The following is a description of a gene set: studied in species Homo sapiens Human Gene Set: GOBP_PHOSPHOLIPID_TRANSPORT The directed movement of phospholipids into, out of or within a cell, or between cells, by means of some agent such as a transporter or pore. Phospholipids are any lipids containing phosphoric acid as a mono- or diester., and this is the list of marker genes: TNFAIP8L3, OSBP, LDLR, ABCA4, PLSCR2, CPTP (ceramide-1-phosphate transfer protein), ABCA12, PLTP, PITPNB, C2CD2L, ATP10B, APOC2, CETP, ABCB4, MFSD2A, PITPNA, VDAC2, SLC66A2, OSBPL2, ESYT1, TMEM41B, VMP1, PRELID3B, ANO4, APOA5, APOC3, SCP2, SERINC3, ATP8A1 (ATPase phospholipid transporting 8A1), SPNS1, ATP8B2, P2RX7, CERT1, PITPNC1, XKR7, APOA1, PLSCR5, PCTP (NCBI Gene Id 94001), ETNPPL (ethanolamine-phosphate phospho-lyase, NCBI Gene Id 64850), ATP11B, XKR8, CLPTM1L, PLSCR3, SCARB1, ANO9, ATP10A, ATP8A2, APOE, ATP10D, ABCC1, TRPC5, PRELID1, GLTPD2, XKR9, KCNN4, OSBPL10, ABCB1, XKR4, GLTP (glycolipid transfer protein), APOA2, ABCA7, ATP11C, PLSCR4 (NCBI Gene Id 57088), XRCC4, APOA4, DBI, ATP9B, NPC2, PLSCR1, PLEKHA8, PITPNM2, SERINC2, ANO7, ATP8B1, PLEKHA8P1, ANO6, ABCA3, SERINC5, ATG9A, TRIAP1, APOC1, PRAP1, XKR6, OSBPL8, SCARB2, ABCA1, ATP9A, FASLG, ANO3, SLC4A1, MTTP, ATP8B4, TMEM63B, PITPNM3, ABCG8, ATP11A, PLA2G10, TMEM30A, OSBPL5, ATG9B, ATP8B3, VAPA, PRELID2, TMEM30B, BLTP1, PITPNM1, PRELID3A, ABCG1